Given this list of marker genes Tyk2, Il20ra, Il19, Ifnlr1, Il20, Il22ra2, Ifnl2, Stat5a, Il24, Ptpn11, Stat3 (NCBI Gene Id 68733), Il20rb, Jak2, Il22ra1, Il22, Ifnl3, Il10rb (interleukin 10 receptor, beta), Stat5b, Stat2, here is a description of the gene set: Mouse Gene Set: REACTOME_INTERLEUKIN_20_FAMILY_SIGNALING studied in species Mus musculus Interleukin-20 family signaling